The following is a description of a gene set: studied in species Homo sapiens Genes predicted to be targets of miRBase v22 microRNA hsa-miR-615-3p in miRDB v6.0 with MirTarget v4 prediction scores > 80 (high confidence targets). from publication Chen Y, Wang X (PMID 31504780) Human Gene Set: MIR615_3P, and this is the list of marker genes: USP44, ITSN1, TOMM7, MEF2A, ZNF626, PSMD11